Given this list of marker genes Ccr2, Smarca4, Nop56, Cemip, Mbd6, Prmt7, Fhit, Dusp11, Acaca, Pex14, Paf1, Fam111a, E2f5, Fkbp6, Smad7, Rae1, Polr1b, Rgs22, Eef1d, Rpp38, Nono, Aff4, Rsad2, Leo1, Lbr, En2, Herc4, Orc6, Bnc2, Ccdc137, Cc2d1a, Spata2, Tcof1, Cd2ap, Bcl9l, Atp5mj, Mri1, Traf4, Gtf3c3, Specc1, Rps6ka6, Lipa, Mettl5 (methyltransferase 5, N6-adenosine), Wdr43, Dcaf1, Ptpn13, Dsn1, Thap1, Snai1, Hoxb5, Cdk7, Sp140l2, Nedd1 (neural precursor cell expressed, developmentally down-regulated gene 1), Apex2, Stag2, Smug1, Mrpl23, Rerg, Taf4b, Nrip1, Ip6k2, Sp140 (NCBI Gene Id 434484), Terf1, Ddx46, Malt1, Map3k14, Fbl, Kdm4a, Nfib, Top1, Arhgap32, Ager (NCBI Gene Id 11596), Znrf2, Heatr1, Fbll1, Rpain, Imp4, Gar1, Mllt1, Btbd10, Selenbp1, Taf1c, Nop53, Nolc1, Ube2i, Nop58, Polr1g (RNA polymerase I subunit G), Esrra, Trerf1, Pak6, Plrg1, Trim41, Foxj2, Jazf1, Ubd, Deaf1, Casp7, Zfp174, Polr1c, Kit, Sp140l1, Smarca5, Eif3l, Mtdh, Dkc1, Txnrd1, Samd4, Nfkbie, Sap30l, Trim27, Pspc1, Camk4, Rai14, Ezr, Otp, Smarcb1, Polr2f (NCBI Gene Id 69833), Nufip1, Akna, Stox1, Wdr33, Urb1, Utp15, Sirt1, Gon4l, Nr4a1, Utp4, Selenbp2, Ip6k1, Pafah1b2 (platelet-activating factor acetylhydrolase, isoform 1b, subunit 2), Fblim1, Arhgap33, Syne2, Ncl, Nfic, Polr1e, Rreb1, Ttc8, Kdm5d, Tax1bp3, Cilk1, Dab2, Coil, Snrpb2, Ankrd1, Klf6, Rnmt (NCBI Gene Id 67897), Kmt5b, Sumo1, Timm44, Nhej1, Uso1, Ttf1, Stn1, Exosc8, Dclre1a, Cd2bp2, Chchd1, Timm13, Sesn1, Foxa1, Nuak1, Ubtf, Cdca7l, here is a description of the gene set: A structure found most metazoan nucleoli, but not usually found in lower eukaryotes; surrounded by the dense fibrillar component; the zone of transcription from multiple copies of the pre-rRNA genes is in the border region between these two structures. species: Mus musculus Mouse Gene Set: GOCC_FIBRILLAR_CENTER